Given this list of marker genes GPR171, GMFG, HERC5, GZMK, CYTIP, TNFRSF17, OAS3, CD3D, IFIT1, IFIT3, IGKV1D-13 (immunoglobulin kappa variable 1D-13), CCR2, TRBC2, CCR5, IFI44, IGLL3P, IFI44L, OAS1, IFI6, IGLV2-14, CD38, CD48, IGHM, ISG15, OAS2 (NCBI Gene Id 4939), CD2, FKBP11, GIMAP4, GZMA, JCHAIN, OASL, SH2D1A, XAF1, ITK, LCK, HERC6, IGKV3-20, MZB1, LCP2, GPR18, POU2AF1, IL10RA, CD8A, IGHA1, MX1, IGHG1, IGLC2, RSAD2, here is a description of the gene set: studied in species Homo sapiens Cluster 1: interferon, T and B lymphocyte genes clustered together across breast cancer samples. Previous microarray studies on breast cancer identified multiple tumour classes, of which the most prominent, named luminal and basal, differ in expression of the oestrogen receptor alpha gene (ER). We report here the identification of a group of breast tumours with increased androgen signalling and a 'molecular apocrine' gene expression profile. Tumour samples from 49 patients with large operable or locally advanced breast cancers were tested on Affymetrix U133A gene expression microarrays. Principal components analysis and hierarchical clustering split the tumours into three groups: basal, luminal and a group we call molecular apocrine. All of the molecular apocrine tumours have strong apocrine features on histological examination (P=0.0002). The molecular apocrine group is androgen receptor (AR) positive and contains all of the ER-negative tumours outside the basal group. Kolmogorov-Smirnov testing indicates that oestrogen signalling is most active in the luminal group, and androgen signalling is most active in the molecular apocrine group. ERBB2 amplification is commoner in the molecular apocrine than the other groups. Genes that best split the three groups were identified by Wilcoxon test. Correlation of the average expression profile of these genes in our data with the expression profile of individual tumours in four published breast cancer studies suggest that molecular apocrine tumours represent 8-14% of tumours in these studies. Our data show that it is possible with microarray data to divide mammary tumour cells into three groups based on steroid receptor activity: luminal (ER+ AR+), basal (ER- AR-) and molecular apocrine (ER- AR+). from publication Farmer P, Bonnefoi H, Becette V, Tubiana-Hulin M, Fumoleau P, Larsimont D, Macgrogan G, Bergh J, Cameron D, Goldstein D, Duss S, Nicoulaz AL, Brisken C, Fiche M, Delorenzi M, Iggo R (PMID 15897907) Human Gene Set: FARMER_BREAST_CANCER_CLUSTER_1